The following is a description of a gene set: studied in species Homo sapiens Human Gene Set: HP_ELEVATED_MEAN_ARTERIAL_PRESSURE Elevated mean arterial pressure An abnormal increase in the average blood pressure in an individual during a single cardiac cycle., and this is the list of marker genes: ECE1, RGS5, ATP1B1, NOS3, PTGIS, GNB3, ADD1, CYP3A5, AGTR1